The following is a description of a gene set: Human Gene Set: GOBP_CHROMATIN_REMODELING_AT_CENTROMERE Dynamic structural changes in centromeric DNA. species: Homo sapiens, and this is the list of marker genes: CENPW, CENPI, CENPP, NASP, CENPN, ITGB3BP (NCBI Gene Id 23421), MIS18A, CENPA, OIP5 (NCBI Gene Id 123752), HJURP